The following is a description of a gene set: Genes predicted to be targets of miRBase v22 microRNA hsa-miR-23b-5p in miRDB v6.0 with MirTarget v4 prediction scores > 80 (high confidence targets). studied in species Homo sapiens from publication Chen Y, Wang X (PMID 31504780) Human Gene Set: MIR23B_5P, and this is the list of marker genes: NTRK3 (neurotrophic receptor tyrosine kinase 3), GIPC3, PLG, CYRIA, BARX2, GOLGA6L1, HIRIP3, FOXC1, OSGEP, CENPS-CORT, ZMYM3, REG1A, NOL4L, GPC6, CCNJL, MRPL43, MLIP, SSMEM1, PPM1N, ERC2, PPA2 (inorganic pyrophosphatase 2), ATXN1, RNF168, SIRPA, TMEM217, TMEM140, TMEM127, EPHA5, ABCA1, IGF2, MYEOV, CHD4, CAMK1D, CORT, USH2A, DSC1, KCNIP1, PSD3, LIPG, ANKRD7, CCDC97, TEC, MAPRE1, PRR23E, APRG1 (NCBI Gene Id 339883), VSIG1, ITGA5, GOLGA6L6, SF3B1, MTMR4, KCNC4